The following is a description of a gene set: studied in species Homo sapiens Human Gene Set: HP_HYPOGLYCEMIA Hypoglycemia A decreased concentration of glucose in the blood., and this is the list of marker genes: IARS1, ETFB, MSL3, NR3C1 (nuclear receptor subfamily 3 group C member 1), SLC52A1, CIC, PCK2, APC2, GFRA1, MRPS7, MRAP (melanocortin 2 receptor accessory protein), PHKA1, CYC1, ACADSB, CYP21A2, PTEN, GMPPA (GDP-mannose pyrophosphorylase A), SECISBP2, HADH, NDUFAF5, KCNQ1OT1, POGZ, PAK1, LHX3, APPL1, UQCRH, NDUFS1 (NADH:ubiquinone oxidoreductase core subunit S1), UQCRC2, MT-ND3, GHR, KCNQ1, RNF125, STIM1, MLYCD, NDUFB9, ABCC8, PAX4, TRAPPC11, CPT2, AKT2, MC2R, MICOS13, NDUFB10, MEN1, GALK1, MT-CYB, PTF1A, ATP7A, IGF1, MPV17, NDUFS6, PLAG1, SAMD9, NDUFB11, GATB, SGPL1, SLC34A1, FARSB, CDON, HADHA, HMGA2, PCCB, PC, CDKN1C, PROKR2, NFS1, ODC1, SUCLG1, DBH, HSD17B10, MMAB, OTC, MT-ND1, PNPO, KCNJ11, LRPPRC, WARS2, CYP11A1, WDR11, NDUFV2, NDUFAF1, INS, GK, PDX1, POLR1A, H19, EHHADH (NCBI Gene Id 1962), PREPL, NDUFAF3, GATC, PCK1, UCP2, MTO1, NDUFA11, MRPS2, QRSL1, COG8, PCSK1, PET100 (NCBI Gene Id 554363), NDUFB3, NAB2, GCSH, FOXRED1, IGF2, NDUFA1, MYT1L, MMUT, NFKB2, UQCC3, NDUFS8, CTDP1, TMEM126B, DIS3L2, ALDOB, NDUFS2, GHSR, EBP, ITGA8, SLC25A20, GFM2, POU1F1, PRKAG2, TIMMDC1, GATM, CPT1A, ACSF3, NDUFAF2, PHKA2, HMGCL, STAR, HRAS, NSD1, PPP2R5D, ETFDH, WNT9B, GRB10, ACADVL, GYS2, ACADM, CYB561, GLYCTK, PCCA, NUBPL, MPC1, DMXL2, ACSL5, HESX1 (NCBI Gene Id 8820), SLC25A36, MCCC1, INSR, PPP1R15B, ACAD8, ASXL2, RET, SLC3A1 (NCBI Gene Id 6519), BLK, NDUFS7, EIF2S3, GCK, LHX4, TFAM, POMC, PLPBP, MRPS28 (NCBI Gene Id 64947), ROBO1, PHKG2, AUH, NR1H4, ATP5F1D, ACAT1, KDM6A (lysine demethylase 6A), DOLK, FOXA2, HYOU1, GPC4, ATIC, NNT, ACAD9, SCO1, CLPB, SERAC1, TRMT10A, KLF11, YARS1, MTOR, GPR161, BCS1L, NDUFAF6, SLC2A2, DLD, TBX19, MMACHC, ALDH7A1, MRPL39, MADD, TEFM, MT-ND2, HERC1, NDUFS4, CA5A, COG7 (component of oligomeric golgi complex 7), CAMKMT, CACNA1C, DDC, AGL, PHKB, COX16, PPM1B, FBP1, DGUOK, SOX3, GH1, TXNRD2, GREB1L, PGM1, NBAS, STAT6, HNF4A, FAH, NDUFAF4, RRAGC, UQCRB, SLC37A4, GCDH, OTX2, HMGCS2, GLUD1, DNAJC19, FGF20, STX5, HADHB, TRPM3 (transient receptor potential cation channel subfamily M member 3), ACADS, NDUFAF8, SLC16A1, COX11, HNF1A, GLI2, SLC22A5, YY1, GALT, NDUFS3, G6PC1, PROP1, AAAS, GPC3, NDUFV1, GJA1, HTRA2, HSD3B2, COX10 (cytochrome c oxidase assembly factor heme A:farnesyltransferase COX10), PYGL, BCKDHA, POR, ALG12, IARS2, TANGO2, SLC1A1, ETFA, SNIP1, FUT8, NEUROD1, MCCC2, TFE3, KMT2D, NDUFA6, CEL